Given this list of marker genes MYZAP, LMOD2, DSG2, PSEN1, COQ4, LAMP2, TNNI3, CAP2, BAG5 (NCBI Gene Id 9529), GTPBP3, RRAGC, TTN, GNPTAB, MYH6, MRPL39, FLII, here is a description of the gene set: studied in species Homo sapiens A large reduction in the fraction of blood pumped from the left ventricle with each cardiac cycle. The normal range in adults is at over 50 percent, and a severe reduction is defined as less than 30 percent. Severely reduced left ventricular ejection fraction Human Gene Set: HP_SEVERELY_REDUCED_LEFT_VENTRICULAR_EJECTION_FRACTION